The following is a description of a gene set: The expansion of a B cell population by cell division following B cell activation during an immune response. Human Gene Set: GOBP_B_CELL_PROLIFERATION_INVOLVED_IN_IMMUNE_RESPONSE species: Homo sapiens, and this is the list of marker genes: TLR4, PLCL2, GAPT, CD19, ABL1, CD180